The following is a description of a gene set: Type 1 IFNs can conditionally activate all of the signal transducers and activators of transcription molecules (STATs), including STAT4. The best-characterized signaling pathways use STAT1, however, and type 1 IFN inhibition of cell proliferation is STAT1 dependent. We report that type 1 IFNs can basally stimulate STAT1- and STAT4- dependent effects in CD8 T cells, but that CD8 T cells responding to infections of mice with lymphocytic choriomenigitis virus have elevated STAT4 and lower STAT1 expression with significant consequences for modifying the effects of type 1 IFN exposure. The phenotype was associated with preferential type 1 IFN activation of STAT4 as compared to STAT1. Stimulation through the TCR induced elevated STAT4 expression, and STAT4 was required for peak expansion of antigen-specific CD8 T cells, low STAT1 levels, and resistance to type 1 IFN-mediated inhibition of proliferation. Thus, a mechanism is discovered for regulating the consequences of type 1 IFN exposure in CD8 T cells, with STAT4 acting as a key molecule in driving optimal antigen-specific responses and overcoming STAT1-dependent inhibition of proliferation. species: Homo sapiens from publication Gil MP, Ploquin MJ, Watford WT, Lee SH, Kim K, Wang X, Kanno Y, O'Shea JJ, Biron CA (PMID 22968462) Genes down-regulated in CD8 T cells: wildtype versus STAT4 knockout. Human Gene Set: GSE40666_WT_VS_STAT4_KO_CD8_TCELL_DN, and this is the list of marker genes: ABCC5, CHST13, JPH4, TMEM59, POLI, C15orf40, ZSCAN16 (zinc finger and SCAN domain containing 16), TPCN1, ECT2, MBOAT1, SIVA1, C17orf100, TSPAN32, GPR82, EPB41L4A-AS1, CUTA, DYRK4, P3H1, ABHD17A, ID3, KCTD3, CDCA7L, AKIP1, ELP3, IMP4, WDFY3, STK36, CDCP1, LMLN, TMEM170B, FER, CUL4B, C10orf143, ZMYND12, RNF187, DCAF10, ILK, ARHGEF9, SLFN11 (NCBI Gene Id 91607), GSS, SIGLEC7, ZBED3, TMCO1, ATP5IF1, POLR2I, CACUL1 (CDK2 associated cullin domain 1), DGKZ, IL12RB1, DENND4C, ZBTB44, VPS53, UBE2Q2, CYREN, DYNLL2, EIF3J-DT, HLA-DMB, ZNF174, ALDH5A1, EAF2, UCK1, NT5DC1, CPNE2, EEF1AKMT1, SLC46A3, BCR, GLG1, EID2B, POLR3C, SLC2A4RG, MCM6, FXN, ZNF394, MAML3, GRHPR, UBA7, CTDSP2, AP1M1, LMAN2L, NOA1, ZNF329, NDUFA11, OLFML2B, RNF141, MPPE1, UBLCP1, SPA17, TXK, DYNC2LI1, HNMT, IMPDH1, RFC2, TMEM266, PTER, ASB13, TIMMDC1, RAB3D, DENND1C, GPSM2, GMPPA, REXO2, RAC2, LMBRD1, CEP95 (centrosomal protein 95), TMX4, CRY2 (cryptochrome circadian regulator 2), BBS12, NUDT6, TP53INP1, FAM168A, MPV17, SESN1, ZNF367, CIAO1, BBS1, B3GLCT, SPRYD4, SAR1B, PI4KA, LINC00324, TMEM9B, EIF3LP3, CYB5R4 (cytochrome b5 reductase 4), TLN1, RDH10, HMGN5, COX11, ACTR1B (NCBI Gene Id 8423), DENND2B, S100A6, XRCC1, TRAPPC10, SDHB, GPR34, RMND1, COG1, GLCCI1, CYB5D2, ARSD, CITED2, VSIR, TNFRSF10D, ZNF565, HCG11, KPNA5, PITPNM1 (NCBI Gene Id 9600), PCNA, ABCD4, CCDC186, MPC1, ARHGAP15, RIN3, ING4, POMGNT2, DECR1 (NCBI Gene Id 1666), UROS, PRPSAP1, TOR1AIP1, RABGGTA, MYL9, NOP56, EIF3H, SNX14, CCPG1, FAM50A, MIS18BP1, MKRN1, TMEM87B, CARD8, TMEM164, TXNDC12, RHBDD2, KLHDC3, DPY19L4, CCDC88A, CNPY3, EXOC6B, PSTPIP1, PRIMPOL, CCNDBP1, FAM86B1, HS1BP3, PIH1D1, PNKP, WWP1, TOMM40, ODF2 (NCBI Gene Id 4957), TOE1, ZNF766, PSMD5, ZNF266, SUSD1, SYNE1, C1orf53, ARHGAP4, CDADC1, CASP6, YPEL2, DZANK1, ACAD8